The following is a description of a gene set: from publication Wirth TC, Xue HH, Rai D, Sabel JT, Bair T, Harty JT, Badovinac VP (PMID 20619696) The transcriptome of naive OT-I T cells was compared to memory CD8 T cells after 1, 2, 3, or 4 infection with ovalbumin expressing Listeria monocytogenes (LM-OVA). Genes up-regulated in memory CD8 T cells: 3' versus 4'. species: Homo sapiens Human Gene Set: GSE21360_TERTIARY_VS_QUATERNARY_MEMORY_CD8_TCELL_UP, and this is the list of marker genes: GAL3ST4, CAMSAP2, FCGR1A, ICA1, CD300LF, ABCC3, ARHGAP5, ITGB5, MSRB2, LAT2, LPAR6 (NCBI Gene Id 10161), HPGDS, RGL2, GSN, DMPK, ECM1, PLD4, PAOX, DBI, MROH1, CABLES1, STAB1, RGS2, GCNT1 (glucosaminyl (N-acetyl) transferase 1), RCAN1, MAN2B1, TNFAIP8, WDR7, P2RY13, DHRS3, NAV2, HTR2B, TSPAN9, PRUNE2, SLC37A2, CD300C, ANGPTL4, PTGFRN, CYB5R1, ACBD5, ST6GAL1, CCR1, SMAD7, SLC15A2, HAL, SCRN3 (secernin 3), MMD, VGLL4, LMO2, SLC66A1, PLEKHO1, TBC1D22A, EPS8, SPRY2, AP2S1, RGS10, ULK2, NAAA, ITGAD, STING1, YPEL3, DPYSL2, TRPV2, CERK, NME4, SMAGP, PLA2G15, PLOD1, PGAP6, H1-5, CD163, ADAMTSL4, CDO1, TRAF7, OTULINL, JMJD1C, CHD9, ETV5, NCEH1, GM2A, HEXB, SLC9A9, LDLRAD3, FUNDC1, RAB3IL1, ANK1, CD109, DEPDC1B, SCARB1, BLTP3A, EPOR (NCBI Gene Id 2057), XYLT1, SH2B2, HIP1, HPSE, TSPAN14, CPEB2, FCGRT, EMP1, CCR3, SPINK2, MUC1, LRP1, LFNG, TMEM9 (NCBI Gene Id 51235), CENPF, PLXDC1, CNR2, SPON1, CYTH1, FZD7 (frizzled class receptor 7), OLFML3, CMBL (carboxymethylenebutenolidase homolog), VWA5A, MGAT5, SORT1, CPT1A, PECR, ZDHHC14, GPX3, SNX1, PKIB, APOC2, COTL1, PPT1, KIFC3, CDCA5, LTC4S, RAP2A, CEBPA (NCBI Gene Id 1050), USP2, ARSG, ZFP36L2, SELENOP, AHCYL2, PAQR7, SEMA6B, RNF144B, TCN2, GNA12, SSH2, PYCARD, ARL11, SLC22A23, ACAP3, TPRA1, DAB2 (DAB adaptor protein 2), GDE1 (NCBI Gene Id 53591), DCXR, HFE, ARL2, RASA3, NECAP2, PNPLA7 (patatin like phospholipase domain containing 7), PDE4D, SLC35C2, PRAM1, PTGS1, AXL, RUNX3 (NCBI Gene Id 864), LBP, SLC25A13, HACD4, RNF150, SPSB1, CD34, SMPDL3A, ARSB, COL14A1, GALNS, F13A1, SH3GL1, ADAM9, SGK3, ZDHHC23, KHK (ketohexokinase), FURIN, CTNNB1, SOCS6, COLEC12, TBXAS1, LY6E, CD101